Given this list of marker genes Hrc, Pln, Casq1, Stim1, Stac3, Hap1, Htt, Atpsckmt, Akap7, Jph2, Homer1, Jsrp1, Stimate, Kcnj1, Galr2, Dysf, Nppa, Gstm7, Scn1b, Drd4, Ank3, Kcne5, Gnb5 (guanine nucleotide binding protein (G protein), beta 5), Lrrc38, Fmr1, Selenon, Fgf12, Crbn, Epo, Cacnb3, Asph, Lrrc52, Fkbp1b, Ehd3, Cbarp, Kcnab1, Lrrc55, Gpr35, Fgf13, Stim2, Slmap, Itgb1, Akap6, Kcne3, Ikbkb, Fgf14, Ahnak, Mmp9, Cracr2a, Gsto1, Lrrc26, Cacnb2, Plcg2, Kcne2, Ctss (cathepsin S), Fkbp1a, Tmem74, Myo5a, Nipsnap2, Calm1, Calm3, Sumo1, Cacna1f, Ank2, Abcc9, Neto1, Ednra, Pirt, Rnf207, Nedd4l, Kcne1 (potassium voltage-gated channel, Isk-related subfamily, member 1), Sri, Stac2, Dmd, Kcnq1, Vamp2, Casq2, Kcnrg, Gal, Tmem168, Jph3, Stac, Hpca, Drd2, Cav1, Cacnb4, Actn2, Kcnj8, Pkd2, Calm2, Grp, Edn1, Ubqln1, here is a description of the gene set: species: Mus musculus Mouse Gene Set: GOBP_REGULATION_OF_CATION_CHANNEL_ACTIVITY Any process that modulates the frequency, rate or extent of cation channel activity.